The following is a description of a gene set: Increased cross-section (diameter) of the long bones. Note that widening may primarily affect specific regions of long bones (e.g., diaphysis or metaphysis), but this should be coded separately. Human Gene Set: HP_BROAD_LONG_BONES studied in species Homo sapiens Broad long bones, and this is the list of marker genes: SMARCA2, DNMT3A, COL1A2, MAP3K7, NEUROD2, EP300, CASK, HNRNPR, PUF60, GJA5, GPC3, GATAD2B, SIAH1, SATB2, LYSET, FGFR3 (fibroblast growth factor receptor 3), DLK1, EZH2, GLI3, DACT1, MAN2C1, IFT122, HS2ST1, TBX5, COL2A1 (NCBI Gene Id 444981), GDF5, EXTL3, ADAMTS10, POGZ, COL1A1, ZNF668, EXOSC2, SHOX, AMMECR1, DVL1, COL10A1, SMOC1, B3GALT6, LIG4, GPC6, NPR2, HSPG2, KNSTRN, SALL4, COL11A1, SALL1, TWIST1, RNU4ATAC, GRIN1, FGF9, H3-3B, EFNB1, NOG, B3GAT3, MED12, MSX2, OFD1, SIK1, WNT5A, GATA4, LMBR1, SETD5, MED25, USP9X, CBFB, SLC25A22, MEG3, ACAN, HOXD13, NSD1, DVL3, SLC26A2, SLC32A1, ABCC9, FLNA, DNM1L, TRIM8, NEPRO, FBXO11, CDKL5, ARX, INPPL1, RBM8A, H3-3A, BPTF, NSUN2, ALX4, BMP2, SCN1B, GJA8, FLNB, WDR19, PIGQ, XYLT1, TRPM3 (transient receptor potential cation channel subfamily M member 3), DMXL2, G6PC3, GJA1, SMO, GPC4, KCNJ8, SNIP1 (NCBI Gene Id 79753), BICRA, PRKG2, GNAS, HHAT, DDR2, BMPR1A, SUZ12, ADNP (NCBI Gene Id 256440), ROR2, FBN1, SCN2A, BGN, RAB33B (NCBI Gene Id 83452), PIGP, FGFR1, DHX30, HPGD (NCBI Gene Id 3248), SRCAP, IFIH1, MEIS2, PCDHGC4, MEGF8, RLIM, OTUD6B, SUMF1, EED, GNAO1, RERE, KCNA1, FGFR2, PRKD1, NXN, PTEN, KCNH1, PNKP, ZNF141, PDE4D, FLI1, IFT56, PYCR2, KIF22 (NCBI Gene Id 728037), CTCF, CHST3, SLC35D1 (solute carrier family 35 member D1), RTL1, PACS1, PSMD12, GRM7, WLS, PIK3CD, RAB23, KCTD1, CREBBP